Given this list of marker genes HOXB2, PELI2, SERTAD4, CCDC144BP, PANK3, TM4SF1, RGCC, GBP3, CPEB2, DEPP1, CXCR4, RASGRP1, ZNF550, RTN1, CCN1, DKK4, APOBEC3G, SLC40A1, VIM, TRIM6, SPARC, SLC4A4, LIPG, LHFPL6, GNG2, DHRS2, SFRP4, SERPINA1, KRTAP2-4, NANOS1, here is a description of the gene set: Promoter hypermethylation is a prevalent phenomenon, found in virtually all cancer types studied thus far, and accounts for tumor suppressor gene silencing in the absence of genetic mutations. The mechanism behind the establishment and maintenance of such aberrant hypermethylation has been under intense study. Here, we have uncovered a link between aberrant gene silencing associated with promoter CpG island DNA methylation and the siRNA/miRNA processing enzyme, DICER, in human cancer cells. By comparing demethylated HCT116 colon cancer cells with HCT116 cells genetically rendered hypomorphic for DICER, we identified a group of epigenetically silenced genes that became reactivated in the absence of functional DICER. This reactivation is associated with a dramatic loss of localized promoter DNA hypermethylation. Thus, intact DICER is required to maintain full promoter DNA hypermethylation of select epigenetically silenced loci in human cancer cells. from publication Ting AH, Suzuki H, Cope L, Schuebel KE, Lee BH, Toyota M, Imai K, Shinomura Y, Tokino T, Baylin SB (PMID 18413723) Human Gene Set: TING_SILENCED_BY_DICER studied in species Homo sapiens Epigenetically silenced genes up-regulated in HCT116 cells (colon cancer) hypomorphic for DICER1.